Given this list of marker genes PDX1, RYR2, NEUROD1, IL6, CAPN10, WFS1, TCF7L2, SRSF6, HDAC3, CAST, ISL1, EIF2S1, here is a description of the gene set: Any apoptotic process in a type B pancreatic cell, a cell located towards center of the islets of Langerhans that secretes insulin. species: Homo sapiens Human Gene Set: GOBP_TYPE_B_PANCREATIC_CELL_APOPTOTIC_PROCESS